The following is a description of a gene set: Genes down-regulated in macrophages (12h): control versus IFNG, TNF and rosiglitazone. Human CD14 positive monocytes were purified from healthy volunteers’ blood and cultured in vitro for 4, 12, 24, 72 hours. While culturing, macrophages were activated alternatively with interleukin-4 (IL-4 100 ng/ml) or classically with interferon-gamma (IFNg 100 ng/ml)+tumor necrosis factor (TNF 50 ng/ml) or left without activation. Simultaneously, macrophages were also treated with vehicle (DMSO:ethanol) or 1mM synthetic PPARg agonist, Rosiglitazone. We used Affymetrix microarrays (U133Plus 2.0) to analyze activation and PPARg-induced gene expression changes. Human Gene Set: GSE16385_UNTREATED_VS_12H_ROSIGLITAZONE_IFNG_TNF_TREATED_MACROPHAGE_DN studied in species Homo sapiens from publication Szanto A, Balint BL, Nagy ZS, Barta E, Dezso B, Pap A, Szeles L, Poliska S, Oros M, Evans RM, Barak Y, Schwabe J, Nagy L (PMID 21093321), and this is the list of marker genes: HDDC3, MINDY4, C4orf19, MRPL40, WT1, STRIP1, AP2A2, TXNIP, GPR17 (G protein-coupled receptor 17), REXO5, BTF3, MARVELD1 (MARVEL domain containing 1), EPAS1, UTP25, DMAC1, TEC, NENF, SAMM50, SOCS3, APP, DRC1, AGFG2, STK32C, ST18, CYC1, LRRC31, CCDC7, NUDT7, NHSL3, PLEKHF1, POLN, MND1, HOXB1, PSMC3, WNT3, GPATCH11, PRKRIP1, KHDC1L, VIL1, PDK1, BARD1, GPR34, LIPK, RPUSD4, MRM2, THSD1, ATP10B (NCBI Gene Id 80225), MYCBP2, KCNE5, UCHL1, ECRG4, BRINP1, ITPA, IQCH, TIMM22, NF1, WDR38, ARMC7, SLC16A13, RAB11FIP3, ALDH8A1, ORC3, ATP2B4, MGME1, NFIA, EXOSC2, MORN2, ZNF394, ANKRD45, AOPEP, OLFM3, RAPGEF3, ID1, MAGED2 (MAGE family member D2), ZFP90, KCNN2, EPB41, NAXE, RPS16, KBTBD12, DMRTA1, BMPR1B, PIR, RPL27, RNF148, COX14, PNMT, USP29, AK2, ZNF334, PCBP4, COMMD5, NXPE4, GCLM, EIF5A, FOXC1, P3H3, POLE3, ABHD15, LIMCH1, RPLP1, CYP11B1, POLR2E, PTTG1IP, RAB5B, MICOS13, ICA1, CYP39A1, MSX2 (msh homeobox 2), GJC1, GPX2, BTG2, SLC25A44, SPA17, WDR4, ATG12, CREB1, YTHDF2, CCDC146, ETV5, TASL, DDIT4, PLPPR1, POMT1, NR2C2AP, EID2, NAT9, CYP4F22, KCNJ15, MTG2, ACBD4, PSMG3, NDUFAF2, PDCD2, RASGRP3, TMEM242, ITPRIPL1, STRADA, SUMF2 (sulfatase modifying factor 2), HABP4, GABRB3, CCDC22, MST1, ERRFI1 (NCBI Gene Id 54206), PLOD2, RAG1, ITGB1BP2, SELENOM, EFEMP1, LHX9, CLTRN, MBLAC2, KNSTRN, ARPC5L, CFAP47, MRPS24, RPL7L1, MED28, PIK3IP1, LDHAL6B, GNGT2, FABP2, WASHC4, LYRM9, PHACTR3, CYRIA, SCYL1, SLC25A34, OIT3, ID2 (inhibitor of DNA binding 2), NIPSNAP3B, CDKN2D (NCBI Gene Id 1032), LATS2, SCN10A, CDH26, MYH3, MFSD9, KCNK12, FGFR1OP2, WNT10B, GNAL, SLC5A4, CFAP298 (NCBI Gene Id 89757), DPH2, HILPDA, COL1A2 (collagen type I alpha 2 chain), UBR7, OLFML2B, ABCG4, ANAPC16, PRDX2, SAFB, IFITM3, RINT1, PNISR, CSNK2A2, SLC29A3, H2AC25, ZNF679, ABCC3 (ATP binding cassette subfamily C member 3)